Given this list of marker genes Ddx21, Dhx36, Ddx1, Mavs, Rigi, Ticam1, here is a description of the gene set: Mouse Gene Set: GOBP_MYELOID_DENDRITIC_CELL_CYTOKINE_PRODUCTION Any process that contributes to cytokine production by a myeloid dendritic cell. species: Mus musculus